Given this list of marker genes BCKDHB, BCKDHA, BCKDK, DLD, DBT, here is a description of the gene set: Branched-chain ketoacid dehydrogenase kinase deficiency (BCKDKD) is a neurological disorder that arises due to mutations in branched-chain ketoacid dehydrogenase kinase (BCKDK). BCKDK is a negative regulator of the branched-chain ketoacid dehydrogenase complex (BCKDH), the enzyme responsible for oxidative decarboxylation of branched-chain amino acid derivatives. BCKDK-dependent phosphorylation of serine residues in the E1 alpha subunit of the enzyme BCKDHA inactivates the BCKDH.<br>Inactivating mutations of BCKDK are associated with impaired intellectual development, microencephaly and autism. Consistent with the role of BCKDK in inhibiting BCKDH activity, inactivating mutations in BCKDK result in higher levels of BCKDH activity and reduced BCAAs in plasma, tissues and urine in mouse models, patients and cell lines. Symptoms of BCKDK deficiency are alleviated in mouse models by dietary supplementation with a BCAA-enriched diet. part of: Diseases of branched-chain amino acid catabolism studied in species Homo sapiens Reactome Pathway: Branched-chain ketoacid dehydrogenase kinase deficiency